Given this list of marker genes Celf2, Rbm33, Kdm1a, Sirt6, Rad21, Ctbp1, Ppme1, Dnmt3a, Usp17la, Dnmt3b, Pcbp2, Hnrnpu, Pdia3, Ddx17, Mir701, Atp2a2, Stat3 (NCBI Gene Id 68733), Elavl1, Suz12, Pou1f1, Ppargc1a, Eef2, Hadhb, Wdr82, Ezh2, Klf4, Smarca4, Dnmt1, Celf1, Csde1, Pum2, Nono, Brd3, Sugt1, here is a description of the gene set: Mouse Gene Set: GOMF_LNCRNA_BINDING species: Mus musculus Binding to a long noncoding RNA (lncRNA).